Given this list of marker genes GCNT2, NFKB1, ITIH6, HAS2, TNFAIP6, B3GNT6, NDST1, CHSY3, CEMIP2, HS3ST1, CSGALNACT2, B3GNT8, TGFB1, GUSB, IGF1, STAB2, SGSH, CHST7, IL1B, CEMIP, CHST12, LYVE1, NAGLU, ITIH1, ITIH4, CHPF, PXYLP1, B3GAT2, HMMR, PDGFB, HYAL3, SPAM1, DSE, CHST3, B3GNT7, B4GAT1, PGLYRP3, SMPD3, IDS, LYG1, HEXB, ITIH2, FOXC1, XYLT1, CSGALNACT1, CHST9, B3GALT6, LYG2, B3GNT4, HEXA, HYAL1, UGDH, CHST13, PGLYRP4, HYAL4, EXT1, CTBS, ABCC5, DSEL, CHST11, XYLT2 (xylosyltransferase 2), CHIA (NCBI Gene Id 27159), AP2A1, OVGP1, GNS, HS3ST3A1, EGF, CD44, B3GNT3, HS3ST2, PGLYRP1, B4GALT7, CHSY1, B3GAT3, CHI3L1, CHI3L2, PGLYRP2, ITIH3, GALNT5, HYAL2, FGF2, ITIH5, B3GNT2, HAS1, B3GNT9, IDUA, CHPF2, CHIT1, EXT2, HAS3 (hyaluronan synthase 3), B4GALT5, SLC35B2, CLN6, B3GAT1, GAL3ST3, CLTC, HS3ST3B1, CYTL1, here is a description of the gene set: Human Gene Set: GOBP_AMINOGLYCAN_METABOLIC_PROCESS The chemical reactions and pathways involving aminoglycans, any polymer containing amino groups that consists of more than about 10 monosaccharide residues joined to each other by glycosidic linkages. species: Homo sapiens